The following is a description of a gene set: species: Homo sapiens part of: N-glycan antennae elongation in the medial/trans-Golgi Reactome Pathway: Reactions specific to the complex N-glycan synthesis pathway If MAN2 acts before MGAT3, the pathway progresses to complex N-glycans, because MAN2 is not able to operate on bisected oligosaccharides (11421343, page 5). The expression of MAN2 over MGAT3 in a tissue can regulate the synthesis of hybrid or complex N-glycans., and this is the list of marker genes: CGA, MAN2A1, MGAT2, MAN2A2, CHST8, CHST10, FUT3, FUT8, LHB, FUCA1